Given this list of marker genes GYPC, SPON2, LUC7L, EPS15, PRP4K, RNF25, CHCHD7, CXXC5, STAT6, NME5, GRAMD4, BCAS2, CLDN6, ADD3 (adducin 3), BAP1, SLC7A8, TNFAIP3, RPIA, LGALS2, PHB2, XCL1, CD4, PSMD14, MTREX, HMGCL, CD274 (CD274 molecule), DNLZ, STAT4, TIMM50, PES1, ABHD17C, DDT, RAN, PLEKHA1, MRPL37, BRI3, STK16, NCKAP1L, NRTN, CDK14, SCN3A, MRPS24, LATS2, DSPP, CORO2A, BCR, DCPS, VAV3, CEACAM21, QSER1, ARFRP1, GBP6, PUS7, NPPC, NDRG1, AP1M2, COPS7A (COP9 signalosome subunit 7A), RSL24D1, ADAT2, C8orf33, MYCBPAP, GCLC, BID, CMA1, RPS6KA1, SLC26A4, GCAT, PF4, SELENOP, EVI2A, MTG2, TRIP10, SLURP1, IGFLR1, CXADR, SENP3, TMEM229B, ARHGAP31, STMN1 (stathmin 1), TNP2, PLEKHH1, ADI1, HERPUD2, SLC25A20 (NCBI Gene Id 788), ST8SIA5, RUVBL2, NR4A1, PHF20, MTX1, EBAG9, CDC37, HTRA1, IYD, HKDC1, TXNRD3, SLC6A18, SRM (NCBI Gene Id 6723), CD3G, CRYL1, KRT27, RABGGTA, ZEB2, VIPR1, HOXC13, HAS3, CCL4, TOP1, ZC3H10, DGKZ, ANKRD33B, OAT, DOCK8, TNNT2, CLPP, UBE2E2 (NCBI Gene Id 7325), SLC5A4, NFE2L1, BZW2, GNPNAT1, BMI1 (BMI1 proto-oncogene, polycomb ring finger), KCNJ10, PER1, TNPO1, KCNN4, PPCDC, WNK1, IPO11, DDX19A, NFKBIZ, LNX2, R3HCC1, BAZ2B, TARBP2, GID4, FUT7, GABRQ, CDKN2AIPNL, ADAM10, SEC14L1, DPF1, TNFRSF11A, STS, KRT7, CD320, CCDC80, FOXB1, PLRG1, CCSAP, FGF13, CHRND, COX5A, FBXW8, NLRP3, PLEKHB1, ADH1C, GLRA1, VASH2, SRF, ZNF334, SMARCC1, CCT4, TNFSF11, AATF (NCBI Gene Id 26574), NGRN, IGFBP5, CHST10, PGF, STK39, PIN1, PELP1, DDX24, NFATC2IP (nuclear factor of activated T cells 2 interacting protein), TACC2, PARP8, CPNE1, GML, MRPS14, NAB1, SH2D2A, SIAH2, XRCC6, CCL1 (NCBI Gene Id 6346), NAB2, PMPCB, LARGE1, KLF1, ACSL5, ANKRD44, GPHN, GUCY1A1, ANGEL1, PRXL2B, PABPC1, SLAMF9, EPB41, SPRYD7, SPHK2, GRID2IP, SLC19A1, KDM2B, here is a description of the gene set: Human Gene Set: GSE15330_LYMPHOID_MULTIPOTENT_VS_MEGAKARYOCYTE_ERYTHROID_PROGENITOR_DN Regulation of lineage potential and transcriptional priming by Ikaros. New insight is provided into a bivalent regulation of lineage priming in the HSC and its lympho-myeloid restricted progeny the LMPP by the lymphoid lineage-determining factor Ikaros Whereas Ikaros is responsible for the activation of a cascade of lymphoid expression programs and for the establishment of lymphoid potential from the HSC to the LMPP it is also responsible for the repression of stem cell and erythroid genetic programs that are incompatible with further lineage restrictions emanating from the LMPP species: Homo sapiens Genes down-regulated in lymphoid-primed multipotent progenitors versus megakaryo-erythrocyte progenitors. from publication Ng SY, Yoshida T, Zhang J, Georgopoulos K (PMID 19345118)